Given this list of marker genes PIK3CB, ALK, INSL3 (insulin like 3), PAK1, PIK3R2, PIK3R1, MAP2K1, CDKN1A, CBL, HGF, MAPK3, ETS1, PLCG1, PAK6, MAPK1, SRC, HRAS, AKT1, PIK3R3, RAP1A, KRAS, PIK3CD, AKT2, BUB1B-PAK6, JUN, STRN, TFE3, CDC42, RAP1B, GRB2, JAK3, RPL11, RAPGEF1, RAC1, PTK2, PAK4, NRAS, GAB1, RAF1, AKT3, CRK, ELOA, PIK3CA, MAP2K2, BRAF, ARAF, SOS1, C8orf34, STAT3, MET, PAK3, BAD, MAPK8, PTPN11, PRCC, PAK5, CRKL, PAK2, SOS2, here is a description of the gene set: studied in species Homo sapiens Human Gene Set: WP_MET_IN_TYPE_1_PAPILLARY_RENAL_CELL_CARCINOMA MET in type 1 papillary renal cell carcinoma